The following is a description of a gene set: Genes down-regulated in H1975 cells (non-small cell lung cancer, NSCLC) resistant to gefitinib after treatment with EGFR inhibitor CL-387785 for 6h. Human Gene Set: KOBAYASHI_EGFR_SIGNALING_6HR_DN species: Homo sapiens from publication Kobayashi S, Shimamura T, Monti S, Steidl U, Hetherington CJ, Lowell AM, Golub T, Meyerson M, Tenen DG, Shapiro GI, Halmos B (PMID 17145885) Activating mutations in the epidermal growth factor receptor (EGFR) tyrosine kinase domain determine responsiveness to EGFR tyrosine kinase inhibitors in patients with advanced non-small cell lung cancer (NSCLC). The modulation of transcriptional pathways by mutant EGFR signaling is not fully understood. Previously, we and others identified a single base pair change leading to a threonine to methionine (T790M) amino acid alteration in the ATP-binding pocket of the EGFR as a common mechanism of acquired resistance. The gefitinib-resistant, T790M-mutant H1975 NSCLC cell line undergoes prominent growth arrest and apoptosis when treated with the irreversible EGFR inhibitor, CL-387,785. We did a transcriptional profiling study of mutant EGFR target genes that are differentially expressed in the resistant gefitinib-treated and the sensitive CL387,785-treated H1975 cells to identify the pivotal transcriptional changes in NSCLC with EGFR-activating mutations. We identified a small subset of early gene changes, including significant reduction of cyclin D1 as a result of EGFR inhibition by CL-387,785 but not by gefitinib. The reduction in cyclin D1 transcription was associated with subsequent suppression of E2F-responsive genes, consistent with proliferation arrest. Furthermore, cyclin D1 expression was higher in EGFR-mutant lung cancer cells compared with cells with wild-type EGFR. EGFR-mutant cells were routinely sensitive to the cyclin-dependent kinase inhibitor flavopiridol, confirming the functional relevance of the cyclin D axis. These studies suggest that cyclin D1 may contribute to the emergence of EGFR-driven tumorigenesis and can be an alternative target of therapy., and this is the list of marker genes: CX3CL1, VEGFA, IER3, MAFF, TGFA, PHLDA2, DUSP6, DUSP4, JUN, DUSP5, FOSL1, G0S2, F3, CCND1, IL11, CCN1, HMGA2, EPHA2